The following is a description of a gene set: from publication Castro I, Dee MJ, Malek TR (PMID 23018461) Genes up-regulated in CD8 T cells after immunization: day 3 versus day 6 and IL2 treatment. species: Homo sapiens Much is known concerning the cellular and molecular basis for CD8+ T memory immune responses. Nevertheless, conditions that selectively support memory generation have remained elusive. Here we show that an immunization regimen that delivers TCR signals through a defined antigenic peptide, inflammatory signals through LPS, and growth and differentiation signals through the IL-2R initially favors antigen-specific CD8+ T cells to rapidly and substantially develop into tissue-residing T effector-memory cells by TCR transgenic OVA-specific OT-I CD8+ T cells. Amplified CD8+ T memory development depends upon a critical frequency of antigen-specific T cells and direct responsiveness to IL-2. A homologous prime-boost immunization protocol with transiently enhanced IL-2R signaling in normal mice led to persistent polyclonal antigen-specific CD8+ T cells that supported protective immunity to Listeria monocytogenes. These results identify a general approach for amplified T memory development that may be useful to optimize vaccines aimed at generating robust cell-mediated immunity. Gene expression analysis was performed for OT-I T cells on day 3 and day 5 after activation with ovalbumin and LPS in vivo with and without treatment with IL-2 using an agonists IL-2/anti-IL-2 complexes (IL2/Jes-6.1) Human Gene Set: GSE39110_DAY3_VS_DAY6_POST_IMMUNIZATION_CD8_TCELL_WITH_IL2_TREATMENT_UP, and this is the list of marker genes: SUOX, TRAM2, TPX2, AURKA, TAP1, MVB12A (multivesicular body subunit 12A), NDC1, COMT, LGALS3, CD80, TXN, MXD3, PCMT1, SPC25, RAB19, DCTN2, CDK1, MED7, LGALS3BP, MARCKS, PLD4, MELK, PML, UBE2J2, CYBB, NF2, BRIP1, GP6, STIL, GZMK, LDHA, CDC6 (cell division cycle 6), MAF, TMX3, ANLN, PIF1, SLC41A1, SMCHD1 (NCBI Gene Id 2490), IKZF3, NDC80, RAD54L (RAD54 like), PLK1, C4orf46, GDI2, PERP, CTLA4, ABCD1, OAS1, AGPAT3, CENPH, SGIP1, DERA, ADAM19, PLCL1, TBX22, LACC1, SPC24, ROPN1L, MSTO1, PFKM, AHCY, DAB2IP, PRICKLE3, DTNBP1, CCDC18, SNRPB2, RENBP, IL1R2, SLC25A6, EXO1, RNF216, DIAPH3, CEP43, ZNF385B, ANKRD13B, TPCN2, PYCARD, RAD51AP1, GZMA, NDUFB7, TRAFD1, LGALS1, CDC45 (cell division cycle 45), TARDBP, PSMG1, SCCPDH, IRAG2, TRIM59, GBP7, MIS18BP1, DEPDC1B, NPNT, PDCD1, HK2, STON2 (stonin 2), DYNC2LI1, PAICS, TIMP2, CHIA, TICRR, DNAJC1 (DnaJ heat shock protein family (Hsp40) member C1), NCAPG2, BCL2A1, CAMK4, CHAF1B, CDKN1A, FHL2, SH3BP2, CASP3, HAP1, PIK3AP1, C12orf75 (NCBI Gene Id 387882), ANP32E, NCAPD2, POC1A, ARPC1A, NR4A2, EHD4, RAD54B, MLX, MLKL, PTCD1, FBXO5 (F-box protein 5), SLC9B2, CTSZ, ALMS1, CHEK1, FANCD2, LPP, KLC3, ADAR, TACC3, NEK2, NTF4, COX6B1, MAD2L1, TFRC, SKA1, REC8, RRM1, ZNF414, ISG15, MYL4, LIN37, CD83, EIF1AX, TMIGD1, SHCBP1, SAPCD2, SSR2, DSP, HDAC3, POGLUT3, WASHC5, DUT, PIK3CG, UQCC2, MEMO1, MND1, TK1, BRI3BP, OPTN, BUB1B, HMGCR, RNASET2, ARHGAP11A, PGGT1B, SH2D1A, ZDHHC15, SELENOH, BEND4, RBBP8, SPATS2, ACADL, BLMH, CYP11A1, PRC1, ASF1B (NCBI Gene Id 55723), GET3, FARSB, DNA2, RGS10, FKBP5, XIAP, FBLN1, MRPL18, CCNA2, ACOT4, CAPG, DDX28, CCR5, UBE3B, HIF3A, LAMC1, NFE2, SUCLG1, KIF11 (kinesin family member 11), NDRG1, DTL (NCBI Gene Id 51514), TNC